The following is a description of a gene set: Three innate (B1-B, NKT, CD8aaT cells) and adaptive (B2-B, CD4T, CD8abT cells) cell-types were sorted by FACS. Three biological replicates for NKT, CD4T, CD8aaT, CD8abT cells and two biological replicates for B1 and B2 cells were generated and the expression profiles were determined using Affymetrix Mu74Av2 chip. Comparisons between the sample groups allow the identification of genes differentially expressed between the innate and adaptive cell-types. Human Gene Set: GSE3039_NKT_CELL_VS_ALPHAALPHA_CD8_TCELL_UP species: Homo sapiens Genes up-regulated in NKT cells versus CD8A T cells. from publication Yamagata T, Benoist C, Mathis D (PMID 16623764), and this is the list of marker genes: HAL, ZNF608, NDST1, SLC2A1, G0S2, HIGD2A, CLK4, TCN2, MGAT4A, SFMBT2, HBEGF, HTRA3, S100A9, PI16, NUDT4, LCN2, IL1R2, MTM1, RSRC2 (arginine and serine rich coiled-coil 2), DIP2A, EMILIN2, NCF4, SPHK1, LUC7L, MARCHF7, P2RY13, TTC33, KMT5B, GNG10, JMJD1C, UBR3, UPF2, RRP1B, PIM1, ASPRV1, IFI44L, RHOV, CARD10, ARG2, OLFM4, SMOX, DMXL2, CHD2, CAMP, OSER1, CCDC80, PELI2, UPP1, ABCA3, SPATA1, RIC8A, QSOX1, ADAMDEC1, ANKRD22, PLXDC2, FAP, ALCAM, CHI3L1, ZFP69, RLF, PI4KB, DIP2C, LSM12, ING3, PDLIM7, CLEC4D, ITPRIPL1, PALS1 (NCBI Gene Id 64398), CPEB2, MTHFD2L, ADGRG3, EPHA2, MTUS1, SFI1, UBXN4, TBC1D23, CAP1, FRG1, ECHDC3, RETREG1, CLEC16A, CSF1, HCAR2, KLF7, PPP1R3B, ZBTB41, PDPK1, TNFAIP6, EIF4G3, MAP1LC3A, CERT1 (NCBI Gene Id 10087), CPNE8, RABGEF1, TTC5, MAPK13, SSH2, EIF4EBP1, GPAT3, SMIM3, F2RL2, HLA-DRA, ETS2, ALPK1, FAM107B, CYTH1, TREM1, IL13RA1, FAM8A1, TRA2A, ZMYM2, ANKRD33B, CPED1, SGSH, SRGN, ZNF43, PRSS22, CCDC157, FCGR2B, KCNQ1OT1, TMEM87A (NCBI Gene Id 25963), PDXDC1, ACBD4, CXCL6, S100A8, CD14, MICALL1, CSRNP1, STEAP4, TMEM40, CTSE (cathepsin E), RASA2, PTPN12, DUSP6, NDUFA6, PROK2, BEND4, PBX1, CTNNB1, MAP4K4, HNRNPC, AHR, MAU2, RABGAP1, KDM7A, BLTP3B, MARCHF3, MMP3, RBM45, PRPF39, STAMBPL1, CXCR2, ARRDC4, RICTOR, IER3, ADGRL2, RAP2A, TMEM53, IGFBP6, SVIP, SHCBP1L, HDC, ACADM, PGF, NDEL1, FBXL5, SLPI, EMB, PLAU, FBXL20, PRELID1, CCR1, IGF1R, CXCL1, USP2, FOSL2, CCDC28A, TIGAR, KLHL12, ADSS1, ATRNL1, HEBP1, PAG1, PLK3, IL36G, ZNF292, RNF24, H2AJ, DYNLT1, NDFIP2, ACY1, MICALL2, PAN3, CASP6, MDH2, SCAMP1, CCNG2, YTHDF3, RAB3GAP1, ZNF622, CTC1